The following is a description of a gene set: Human Gene Set: GOBP_ACROSOME_ASSEMBLY studied in species Homo sapiens The formation of the acrosome from the spermatid Golgi., and this is the list of marker genes: TBPL1, MFSD14A, RFX2, AGFG2, PLA2G3, KIAA0319L, ZPBP2, GARIN3, SPINK2, DCAF17, VPS13B, KNL1, CHN2, PAFAH1B1, NECTIN2, PLN, SOX30, CCDC38, CCDC42, POC1B, SLC9A8, GARIN1A, CCDC136, TMPRSS12, IZUMO3, PDCL2, SPACA1, PFN4, ZPBP, SPPL2C, ACRBP, ACTL7A, AGFG1, TMF1, ACTL9, TBC1D20, GARIN1B, CYLC1